The following is a description of a gene set: Adult male germ cell tumors (GCTs) comprise distinct groups: seminomas and nonseminomas, which include pluripotent embryonal carcinomas as well as other histologic subtypes exhibiting various stages of differentiation. Almost all GCTs show 12p gain, but the target genes have not been clearly defined. To identify 12p target genes, we examined Affymetrix (Santa Clara, CA) U133A+B microarray ( approximately 83% coverage of 12p genes) expression profiles of 17 seminomas, 84 nonseminoma GCTs, and 5 normal testis samples. Seventy-three genes on 12p were significantly overexpressed, including GLUT3 and REA (overexpressed in all GCTs) and CCND2 and FLJ22028 (overexpressed in all GCTs, except choriocarcinomas). We characterized a 200-kb gene cluster at 12p13.31 that exhibited coordinated overexpression in embryonal carcinomas and seminomas, which included the known stem cell genes NANOG, STELLA, and GDF3 and two previously uncharacterized genes. A search for other coordinately regulated genomic clusters of stem cell genes did not reveal any genomic regions similar to that at 12p13.31. Comparison of embryonal carcinoma with seminomas revealed relative overexpression of several stem cell-associated genes in embryonal carcinoma, including several core stemness genes (EBAF, TDGF1, and SOX2) and several downstream targets of WNT, NODAL, and FGF signaling (FGF4, NODAL, and ZFP42). Our results indicate that 12p gain is a functionally relevant change leading to activation of proliferation and reestablishment/maintenance of stem cell function through activation of key stem cell genes. Furthermore, the differential expression of core stem cell genes may explain the differences in pluripotency between embryonal carcinomas and seminomas. species: Homo sapiens Genes from the 12p region that were up-regulated in embryonic carcinoma tumors compared to normal testis. Human Gene Set: KORKOLA_EMBRYONAL_CARCINOMA_UP from publication Korkola JE, Houldsworth J, Chadalavada RS, Olshen AB, Dobrzynski D, Reuter VE, Bosl GJ, Chaganti RS (PMID 16424014), and this is the list of marker genes: YARS2, PLBD1, WBP11, PHB2, GOLT1B, RECQL, ETV6, BCAT1, NANOG (Nanog homeobox), RAD51AP1, TPI1, C12orf57, PHC1, ENO2, GAPDH, RESF1, DERA, TEAD4, NDUFA9, CLEC7A, NOP2, SINHCAF, KRAS, GPRC5A, CD9, CCND2, GDF3 (NCBI Gene Id 9573), PTPN6, TNFRSF1A, WNT5B, ARHGDIB, DDX47 (DEAD-box helicase 47), AK4, SLC2A3, DPPA3, EMG1, KLRD1, LRP6, LDHB, SPSB2, GABARAPL1, MAGOHB